Given this list of marker genes Serpine1, Brca1, Calhm6, Zcchc3, Gpatch3, Mbp, Chi3l1, Tlr6, Eif2ak2, Cd160, Il21, Pla2r1, Tnfrsf1b, Tyrobp, Pten, Zbtb25, Cd40lg, Il18rap, Adora2b, Ap3b1, Ripk1, Tbc1d23, Litaf, Cd200r1, Clec12a, Clec9a, Arnt, Cd226, Csk, Qki, Pparg, Pglyrp1, Siglec1, Creb1, Isl1, Psen2, Nfatc2, Rbm47, Irf9, Fcnb, Tmed10, Tnfrsf21, Tlr7, F2rl1, Zfpm1, C5ar2, Cd81, Txk, Gja8, Zbtb45, Cd2ap, Fcgr1, Nlrp1b, Traf6, Ripk2, Stat5b, Dhx58, Flt4, Mapkbp1, Ly96, Il16, Trem3, Cmklr1, Zbtb2, Hmgb1, Riok3, Runx3, Casp4, Oas1e (NCBI Gene Id 97271), Kit, Klre1, Flot1, Col3a1, Mir155, Chuk, Cd40, Hmgb2, Map2k3, Adcyap1, Optn, Tgfb3, Ccl3, Inava, Trim15, Epha2, F2r, Havcr2, Ccr7, Glmn, Ifi214, Nmbr, Tmem106a, Litafd, Ccbe1, Ccr2, Gata4, Mir883b, Ptpn22, Thbs1, Oas1g, Ido1, Zfp1006, Cyp1b1, Ccn1, Jak3, Rap1gds1, Nav3, Malt1 (NCBI Gene Id 240354), Ext1, Tomm70a, Slc37a4, Clu, S100b (S100 protein, beta polypeptide, neural), Agpat1, Skint10, Polr3d, Defb25, Cx3cl1 (C-X3-C motif chemokine ligand 1), Fadd, Srgn, Dlg1, Polr3c, Skint11, Lpl, Il4, Fosl2, Runx1, Twist2, Gadd45g, Sema7a, Vtcn1, Ash1l (NCBI Gene Id 352974), Nlrp1a, Parp1, Usp25, Mir98, Gata6, Klf4, Dbh, Alox8, Il9, Cd28, Fabp4, Hspa12a, Camp, Abcc8, Rftn1, Ifi203-ps, Clec7a, Ap3d1, Tusc2, Il7, App, Tigit, Tnfrsf14, Cd46, Sulf1, Fn1, Trib2, Irak3, Tnfrsf1a, Cd96, Polr3b, Selenos (NCBI Gene Id 97368), Tek (TEK receptor tyrosine kinase), Nron, Hmox1, Abl2, Akap12, Tlr2, Eif2ak3, Lef1, Cd6 (CD6 antigen), Crhr2, Eomes, 5730507C01Rik, Il12b, Ifi206, Skint2, Arhgef2, Ccr5, Itgav, Zbtb26, Cd36, Garin5a, Tut4, Vsir, Mc1r, Gbp7, Kcnn4 (potassium intermediate/small conductance calcium-activated channel, subfamily N, member 4), Slamf1 (NCBI Gene Id 27218), H2-M3, Fcgr2b, Nqo1, Erbin, Gbp5, H2-T23, Bcl3, Ucn, Apoa1, Clec4e, Bank1, Sorl1, Suz12, Notch2, Irak1, Raet1d, Agt, Nlrx1, S100a13, Acp5, Ins1, Kat2a, Gapdh-ps15, B2m, Serpinb1b, Osm, Zfp580, Capn2, Ltb, Tnfsf15, Sting1, Hsp90aa1, Rgcc, Il18 (interleukin 18), Traf3ip2, Ssc5d, Dhx9, Il17f, Ppm1b, Akap8, Ifi208, Rtn4, Cactin, Rab1a, Xcl1, Pglyrp4, Htr2a, Lrrk2, Chid1, Abcc1, C3ar1, Elf1, Nfkbiz, Lcp2, Vsig4, Rbx1-ps, Rora, Cuedc2, Fgfr4, Nr4a3, Ceacam20, Nptn, Ghsr, Ubr5, Zbtb39, Tnfsf4, Il23r, Inhbb, Aire, Btn1a1, C1qbp, Ube2j1, Cgas, Il6 (interleukin 6), Pibf1, Btnl6, Ptger2, Cyrib, Elane, Tlr1, Scart2 (scavenger receptor family member expressed on T cells 2), S100a7a, Fzd5, Lilrb4a, Ptpn6, Ccl1, Nod2, Ptprc, Cyp2j6, Lgr4, Cd200, Cd209d, Fbn1, Jph4, Irf3, Heg1, Spag11a, Zbtb34, Irf5, Gprc5b, Ifngr1, Btk (NCBI Gene Id 215271), Sucnr1, Ptpn11, Cptp, Polr3g, Sftpd, Acod1, Ifng, Nfatc4, Spink7, Tlr4, Rabgef1, Mpl, Cd14, Tnfaip8, Klf2, Dlk1, Extl3, Wdr83, Tank, Polr3a, Vegfd, Trim65, Cebpg, Macir, Ppp1r11, Unc93b1, Irgm2, Abcd1, Oas1h, Cx3cr1, Il27ra, Ptgs2, Arfgef2, Il17a, Il17ra, Trim30a, Gimap5, Sash3, Ffar4, Rock2, Slc11a1, Bmpr1a, Muc16, Plcg2, Cd244a, Fcgr3, Ticam1, Cd27, Mr1, Ighd, Chil6, Gstp2, Ufc1, Gstp3 (glutathione S-transferase pi 3), Twist1, Irf1, Nckap1l, Cd1d2, Hspd1, Tspo, S1pr3, Lilrb4b, Zfp36, Stoml2, G3bp1, Inpp5d (inositol polyphosphate-5-phosphatase D), Skint9, Usp50, Trim38, Gstp1, Stmp1, Lrrc32, Zbtb1, Rbpj, Pawr, Trim55, Ddx21, Apod, Zbtb14, Ptprj, Il1r1, Oas1a, Crlf2, Opa1, Ifnb1, Tarm1, Gapdhrt2, Gdf2, Socs5, Mif, Wnt3a, Rel, Ufd1, Myd88, Prkcq, Il1r2, Kdelr1, Mapk13, Adam33, Skint4, C1qtnf3, Twsg1, Cadm1, Epg5, Klrh1, Pou2af1, Gpr141, Slamf6, Traf3ip3, Ccl2, Cd59a, Hfe, Ezr, Mapk11, Furin, Skint8, Lep, Ptprs, Peli1, Il4ra, Prkd2, Laptm5, Nlrp9b, Tcirg1, Prg4, Prkcz, Htr2b, Tmf1, Mul1 (mitochondrial ubiquitin ligase activator of NFKB 1), Mapk14, Zbtb24, Bpi, Cxcl5, F3, Setd4, Nod1, Afap1l2, Axl, Oas1f, Tsku (tsukushi, small leucine rich proteoglycan), Frmd8, G6pdx, Csf2, Angpt1, Jak2, Ffar1, Ephb2, Adam17, Rnf19b, Slamf9, Phb1, Cd3e, Rab2b, Foxp3, Abcc9 (NCBI Gene Id 58900), Pnp2, Rara, Nfat5, Zbtb33, Traip, Ccl5, Mir1896, Trim56, Il1a, Il31ra, Lta, Foxp1, Azi2, Dll1, Ccm2l, Zc3h12a, Nras, Hdac3, Klrk1, Dennd1b, Traf2, Cd300c2, Ager, Xbp1, Isg15, Nploc4, Gpsm3, Itk, Icosl, Panx2, Avpr2, Fbln1 (NCBI Gene Id 14114), Patz1, Atf2, Skint5, Zbtb49, Appl2, Cryba1, Maf, Kctd9, Iqgap1, Crp, Spon2, Clec4a4 (C-type lectin domain family 4, member a4), Atg12 (NCBI Gene Id 67526), Heatr9, Pou2f2, Zfp287, Hdac2, Ins2, Il1rl2, Cyba, Lrrfip2, Cd83, Pdcd4, Fcer1g, Btnl9, Tnfsf9, Scimp, Ffar2, Ereg, Hspb1, Atp6ap2, Homer3, Tnf, Adipoq, Ikbke (NCBI Gene Id 98726), Akirin2, Reg3g, Ulbp1, Serpinf2, Dysf, Rigi, Umod, Adgrg1, Errfi1 (ERBB receptor feedback inhibitor 1), Ccl20, Scamp5, Btnl1, Psen1, Hras, Mir409, Agpat2, Lrrc19, Crebbp, Adcy7, Tlr8, Lacc1, Met, Clec4a3, Rela, Ffar3, Cebpb, Lum, Cd300ld, Traf3ip1, Ezh2, Tgfb2, Cd4, Oas1b, Peli3, Nlrp3, Kpna2rt, Syk, Postn, Lgals9, Cd247 (CD247 antigen), Zfp683, F11r, Smad3, Agtr1a, Ifih1, Crtam, C1qtnf4, Lamtor5, Pglyrp2, Rad21 (RAD21 cohesin complex component), Rnf128, Atf4, Gba1, Plcb1, Tgfb1 (NCBI Gene Id 21803), Ndrg2, Skint6, Uap1, Cd276 (NCBI Gene Id 266672), Casp8, Mog, Trpv4, Skint7, Pde4b, Mynn, Arrb2, Tnfsf18, Gm15441, Zp3 (zona pellucida glycoprotein 3), Ubash3a, Fgfr1, Rbx1, Rnf26rt, Kat5, Psg18, Sulf2, Gata3, Pik3r1, Pld3, Kcnj8, Il36a, Cd1d1, Oscar, Mmp12, Adamts3, D1Pas1, Psg22, Zfp3, Il25, Hdac9, Arg2, Nlrp6, Nr1h4, Fcer1a, Rnf125 (ring finger protein 125), Zbtb6, Trim32, Cd274, Hc, Pla2g3, Tnfrsf13c, Ndfip1 (NCBI Gene Id 71674), Ifi203 (interferon activated gene 203), Sphk1, Btnl10, Gpr174, Hk1, Agtr2, Otud5, Aqp4, Egr1, Polr3f, Wnt5a, Zbtb20, Prkca, Hsf1, Zfp958, Chrna7, Setd2, Gas6, C3, Tlr5, Cxcl17, Lrp1, Rbbp9 (retinoblastoma binding protein 9, serine hydrolase), Gsdma3, Skint3, Pcsk5, Kpna6, Hdac7, Chil3, Ptger4, Nlrc3, Ceacam1, Il33, Nox1 (NADPH oxidase 1), Nutf2-ps1, Il15, Smad7, Hyal2, Il17c, Epx, Serpinb7, Tmed10-ps, Itgb6, Park7, Enpp1, Hgf (NCBI Gene Id 15234), Syt11, Dicer1, Ppme1, Chil5, Bst2, Alox5, Cidea, Ddit3, Trim27, Arrdc4, Stat5a, Dhx33, Irf4, Il1b, Ncl, Ddx1, Per1, Nlrp10, Il5ra, Casp1, Slc7a5, Anxa1, Trim6, Il1rap, Relb, Otud7b, Clnk, Oas1c, Bap1, Card9, Cd47, Gpr18, Zfp973, Nmb, Nlrc4, Bsg, Bcl6b, Igtp, Il22, Panx3, Fcna, Batf, Tirap, Laptm4b (lysosomal-associated protein transmembrane 4B), Src, Cul3, Serpinb1a, C5ar1 (NCBI Gene Id 12273), Trem2, Sh2d1b1 (NCBI Gene Id 26904), Pde4d, Chil4 (NCBI Gene Id 12656), Arg1, Rnf216, Stard7, Mapk9, Pglyrp3, Mefv, Mir301, Cd2, Naip5, Clec2i, Trex1, Rnf135, Ifnar1, Prkcd, Selenok, Elf4, Rnf26 (ring finger protein 26), Smad4, Oas3, Il27 (interleukin 27), Hspa1b, Sirpa, Sars1, Gsdmd, Ccl4, Gimap3, Zbtb7b, H2-Q7, Zc3hav1, Pla2g10, Rasgrp1, Spn, Mndal, Grk2, Cd55, Stat3, Flt3, Arrb1, Aif1, Git1, Ccn4, Xaf1, Homer2, Clec4n, Ghrl, Mir324, Mertk, Il10, Il36b, Gpnmb, Il1rl1, Cd209b, Ankrd2, Gstp-ps, Lipa, Sirt1, Ackr1, Skint1, Tradd, Pml, Stat1, Mdk, Wnt11, Ern1, Tslp, P2rx7, Btn2a2, Ifi213 (interferon activated gene 213), Ccl19, Xiap, Fxr1, Tnfrsf8, Bcl10, Il36g, Lbp, Rps3, Il2, Socs1, Tbk1, Atg9a, Ifi207, Ilrun, Zbtb12 (NCBI Gene Id 279934), Scgb1a1, Seh1l, Ddx3x, Pqbp1, Gpam, Nfam1, Traf3, Kpna2 (NCBI Gene Id 66474), Prnp, Ppara, Cd55b, Tyk2, Zbtb32, Mapkapk2, Fermt1, Cd24a, Il22ra1, Flt1, Nos2, Carmil2, Cma1, Il18r1, Oas1d, Arid5a, Scrib, N4bp1, Foxj1, Uba5, Il17rc, Pkp3, Slc1a1, Il17b, Sod1, Tnfsf13b, Irak4, Sptbn1, Ptafr, Notch1, Il12a, Map2k5, Ephb6 (Eph receptor B6), Il12rb1, Map3k7, Mir21a, Mcoln2, Nfkbil1, Nodal (NCBI Gene Id 21792), Clec5a, Klhl22, Sigirr, Lilra5, Appl1, Csf1r, Rsad2, Mavs, Tia1, Apoa2, Pomc, Cybb, Gpr108, Morc3, Blvra, Ankrd42 (ankyrin repeat domain 42), Dhx36, Chia1, Irf8, Gbp4, Prg2, Gorasp2, Pld4, Gstcd, Nutf2, Aim2, Nfkb1, Yy1, Irgm1, P2ry2, Adam8, Panx1, Snai2, Zg16, Cd84, Igf1, Il6ra, Usp22, Il23a, Casp3, Zbtb37, Tnfaip3, Trpm4, Tril, Clec4a2, Ltf, Fgr (NCBI Gene Id 14191), Myb, Ufsp2, Banf1, Il36rn, Hif1a, Lag3, Nmi, Pola1, F2, Anxa4, Ripk3, Tnfrsf4, Lurap1, Mast2, Ddx56, Lyn, Il17rb, Il19, Adra2a, Il13, Nfatc2ip, Rab7b, Rac1, Abcd2, Il20rb, Drd2, Pdcd1lg2, Oas2, Sphk2, Zfp131, Trem1, Mmp8, Prg3, Btnl2, Tbx21, Il12rb2, Atp2b1, Ly9, Gapdhrt, Serpinb1c, Cd34, Tlr3, Il17d, Pnp, Abl1, Tlr9, Vps13a, Hpse, Btnl12, Slc2a10, Irf7, Ticam2, Nlrp12, Ermap, Kat8, Ccdc88b, Gapdh, Ifi209, Cd74, Card11, Hilpda, Bcl6, Pycard, Atg5, Btnl4, here is a description of the gene set: species: Mus musculus The appearance of a cytokine due to biosynthesis or secretion following a cellular stimulus, resulting in an increase in its intracellular or extracellular levels. Mouse Gene Set: GOBP_CYTOKINE_PRODUCTION